The following is a description of a gene set: Human Gene Set: REACTOME_TRANSPORT_OF_RCBL_WITHIN_THE_BODY Transport of RCbl within the body species: Homo sapiens, and this is the list of marker genes: TCN1, ABCD4, TCN2, CD320, LRP2, LMBRD1, ABCC1, LDLRAP1